The following is a description of a gene set: Human Gene Set: HP_ABNORMAL_ISOHEMAGGLUTININ_LEVEL An abnormal level of isohemagglutinin in the blood. An isohemagglutinin refers to the naturally occurring antibodies in the ABO blood group system (i.e., anti-A in a group B person, anti-B in a group A person, and anti-A, anti-B, and anti-A,B in a group O person). Abnormal isohemagglutinin level studied in species Homo sapiens, and this is the list of marker genes: SLC35C1, MALT1, CD19, CD79A, PRKCD, CR2, ARHGEF1